Given this list of marker genes AR, WT1, FGF2, TUT7, TP53, MRTFB, DROSHA, MRTFA, HIF1A, PARN, DDX5, SMAD4, TENT4B, XPO5, DIS3L2, IL6, SMAD3, IL10, MYB, MALAT1, KLF4, NFATC4, PPARA, NFKB1, DICER1, EGFR, GATA2, DNM3OS, NOTCH3, ELOB, PDGFB, ZC3H12A, SREBF1, AGT, HRAS, PPARG, SND1, EGR1, DDX17, ZSWIM8, BMP2, PRL, PNPT1, PPARD, BMP4, JUN, POU2F1, TENT2, AGO4, SRF, ELOC, ZNF512B, MYC, SMARCA4, ATOH8, PAX6, GNL3, LILRB4, NGFR, APLN, LIN28A, TUT4, RC3H1, AGO1, RC3H2, NR1H2, NCOR1, SPI1, MYCN, NOTCH2, APP, ESR1, SREBF2, XIST, RARA, BMPR1A, QKI, TGFB2, AGO2, KHSRP, GATA3, FOXO3, ETS1, OIP5-AS1, NCOR2, HOTTIP, RELA, POU5F1 (POU class 5 homeobox 1), TNF, SMAD1, LIN28B, FOXA1, FOS, NFATC3, STAT3, REST, TGFB1, TERT, YY1, FOSL1, MYOCD, BCDIN3D, NEAT1, VEGFA, NFIB, TWIST1, TEAD1, NR3C1, SOX9, SMAD6 (NCBI Gene Id 4091), here is a description of the gene set: The chemical reactions and pathways involving miRNA, microRNA, a class of single-stranded RNA molecules of about 21-23 nucleotides in length, which regulates gene expression. Human Gene Set: GOBP_MIRNA_METABOLIC_PROCESS species: Homo sapiens